Given this list of marker genes PRR5L, LINC00887, NUDT8 (nudix hydrolase 8), LINC02977, RNU4-1, HOXB7 (NCBI Gene Id 3217), CPXM1, SDE2, ANK2, PCED1B, TSPOAP1, TBPL1, ITGA4, GARNL3, TSPOAP1-AS1, RNU11, CFB, IRF2BP2, PTK2, IGLL1, PIK3R1, HEMGN, SNORD118, CRPPA-AS1, ENSG00000252188, HHEX, CCNG1, ENSG00000235281, MIR3142HG, FSTL3, P2RY10, SYPL1P1, here is a description of the gene set: Human Gene Set: XPO1_TARGET_GENES species: Homo sapiens from publication Yevshin I, Sharipov R, Kolmykov S, Kondrakhin Y, Kolpakov F (PMID 30445619) Genes containing one or more binding sites for (XPO1) in their promoter regions (TSS -1000,+100 bp) as identified by GTRD version 20.06 ChIP-seq harmonization.